The following is a description of a gene set: Reactome Pathway: Interleukin-15 signaling species: Homo sapiens part of: Interleukin-2 family signaling The high affinity Interleukin-15 receptor is a heterotrimer of Interleukin-15 receptor subunit alpha (IL15RA), Interleukin-2 receptor subunit beta (IL2RB, CD122) and Cytokine receptor common subunit gamma (IL2RG, CD132). IL2RB and IL2RG are also components of the Interleukin-2 (IL2) receptor. Treatment of human T cells with Interleukin-15 (IL15) results in tyrosine phosphorylation of Tyrosine-protein kinase JAK1 (JAK1, Janus kinase 1) and Tyrosine-protein kinase JAK3 (JAK3, Janus kinase 3). IL15 can signal by a process termed 'trans presentation', where IL15 bound by IL15 on one cell is trans-presented to IL2RB:IL2RG on another cell but can also participate in more 'traditional' cis signaling where all the three receptors are present on the same cell. Stimulation of lymphocytes by IL15 release MAPK activation through GAB2/SHP2/SHC (GRB2-associated-binding protein 2/Tyrosine-protein phosphatase non-receptor type 11/SHC transforming protein 1 or 2) cascade activation., and this is the list of marker genes: SHC1, GRB2, SOS2, JAK3, GAB2 (GRB2 associated binding protein 2), STAT5B, IL15RA, JAK1, SOS1, IL15, IL2RG, IL2RB, STAT5A, STAT3